The following is a description of a gene set: Binding to an HMG box domain, a protein domain that consists of three helices in an irregular array. HMG-box domains are found in one or more copies in HMG-box proteins, which form a large, diverse family involved in the regulation of DNA-dependent processes such as transcription, replication, and strand repair, all of which require the bending and unwinding of chromatin. Mouse Gene Set: GOMF_HMG_BOX_DOMAIN_BINDING species: Mus musculus, and this is the list of marker genes: Pax6, Pou3f3 (POU domain, class 3, transcription factor 3), Egr2, Alx4 (aristaless-like homeobox 4), Prrx2, Mef2c, Pou5f1, Tcf12, Pax3, Pou3f2, Utf1, Prrx1, Hivep1, Olig2, Dlx5, Hoxa3, Hoxc4, Cebpa, Gata3, Meox1, Jun, Hhex